Given this list of marker genes GPR82, CLEC4E (C-type lectin domain family 4 member E), MST1R, ELOA-AS1, ADARB2-AS1, RAB15, ZBTB7C-AS2, C11orf52, AKIP1, ZNF214, GALNT5, DSG3, GADD45B, GRIK5, ROR2, DNAL4, SDR42E1, TAS2R38, BEND2, TLX3, ACP4, SMTNL2, TRIM69, ABHD1, TTC39A, MYOD1, CHRM4, SERPINE2, METTL2B, ORM1, PDGFA, SLC25A48-AS1, KIR2DL1, TMEM171, SFXN2, WNT8B, CKAP2L, TRDV2, NHLRC4, SLC8A1, SUSD2, GPRIN2, TXNRD3, PIK3R3, TEAD1, NALT1, FOXP4, PMEPA1, IL6-AS1, NLRP8, MC4R, EREG, HARBI1, GALNT8, ZNF491, LINC00113, ATG7, VAV2, ITPRIP, PTTG2, PRRG1, ERCC6, CDHR3, LINC02260, AGR2, MPV17L2, DUSP4, MIF4GD, KCNQ1-AS1, CHST12, PTPN6, SRCIN1, PSKH1, GSTA4, DNAI1, ZFP42, KIR2DS3, SRGAP1, LONRF3, RXRG, ANXA13, CCL23, EFNA1, RPL23AP32, ADGRE3 (adhesion G protein-coupled receptor E3), NLRP3, MAMDC2-AS1, EGFL6, C6orf15, EHD3, CAMK1, HORMAD1, KCNN4, GYPC, NDRG2, GPR35, MSC-AS1, HSPB3, SPATA45, NOXRED1, GAS8-AS1 (NCBI Gene Id 750), SLC45A2, SLC22A9, NPY4R, PPBPP2, KYAT1, TRIM31, NPW, LINC02223, RAP1GAP2 (RAP1 GTPase activating protein 2), PDHA2, XCR1, IGHV7-81, ZNF891, PHAF1, AOPEP, DKFZP434A062, VAC14-AS1, PTPRN, KIAA1958, TCL1A, RAD51C, SLC17A9, TEKT4P2, SLC25A21-AS1 (SLC25A21 antisense RNA 1), ARRDC2, SNORA74A, VSIR, CCL17, ZNHIT1, BANK1, USP30-AS1, ALDH1L1, TMC1 (transmembrane channel like 1), DUSP15, CHST6, COL12A1, ZNF165, CLEC12B, ADRB1, HTR1D, ODF4, COL1A1, DDIT4, CDCA8, FDCSP, GARIN1B, PEG3, TRAF1, PICK1, OPN4 (NCBI Gene Id 94233), GATA5, KDM4D, SYT17, SPHKAP, LINC01305, SRC, ID3, DYNLL2, PI15, P4HTM, MYO1D, PHGDH, PABPC5, ZNF229, COQ7, LINC00472, RAB40AL, AVPR1B, DPYS, FGF2, ZIC5, TMEM51-AS1, ODAD2, HTR1E, TAC3, GPR68, CST6, LAMB4, KITLG, ZNF554, RIN2, CFLAR-AS1, ROPN1B, GADD45G, MLANA, TRIM8, FAM83E, here is a description of the gene set: The aim of this dataset was to study in detail the transcription kinetics initiated by cytokine IL-4 in early differentiation of Th2 cells. Genes down-regulated in comparison of CD4 T cells treated with IL4 and anti-IL12 at 1 h versus the untreated cells at 1 h. from publication Elo LL, Järvenpää H, Tuomela S, Raghav S, Ahlfors H, Laurila K, Gupta B, Lund RJ, Tahvanainen J, Hawkins RD, Oresic M, Lähdesmäki H, Rasool O, Rao KV, Aittokallio T, Lahesmaa R (PMID 20620947) studied in species Homo sapiens Human Gene Set: GSE17974_IL4_AND_ANTI_IL12_VS_UNTREATED_1H_ACT_CD4_TCELL_DN